The following is a description of a gene set: Mouse Gene Set: REACTOME_G_PROTEIN_MEDIATED_EVENTS studied in species Mus musculus G-protein mediated events, and this is the list of marker genes: Gnai1, Adcy4, Plcb3, Gnal, Plcb4, Adcy2, Gna15, Camkk1, Pde1c, Pde1b, Mapk1, Gnai3, Prkar1b, Calm1, Prkcd, Prkar1a, Grk2, Gnai2, Adcy8, Pde1a, Pla2g4a, Gna11, Plcb1, Prkacb, Calm3, Adcy1, Adcy7, Camkk2, Calm2, Adcy9, Gna14, Adcy5, Adcy6, Prkcg, Gnat3, Gnaq, Prkaca, Plcb2, Adcy3